The following is a description of a gene set: Correlates of immune-mediated protection to most viral and cancer vaccines are still unknown. This impedes the development of novel vaccines to incurable diseases such as HIV and cancer. In this study, we have used functional genomics and polychromatic flow cytometry to define the signature of the immune response to the yellow fever (YF) vaccine 17D (YF17D) in a cohort of 40 volunteers followed for up to 1 yr after vaccination. We show that immunization with YF17D leads to an integrated immune response that includes several effector arms of innate immunity, including complement, the inflammasome, and interferons, as well as adaptive immunity as shown by an early T cell response followed by a brisk and variable B cell response. Development of these responses is preceded, as demonstrated in three independent vaccination trials and in a novel in vitro system of primary immune responses (modular immune in vitro construct system), by the coordinated up-regulation of transcripts for specific transcription factors, including STAT1, IRF7, and ETS2, which are upstream of the different effector arms of the immune response. These results clearly show that the immune response to a strong vaccine is preceded by coordinated induction of master transcription factors that lead to the development of a broad, polyfunctional, and persistent immune response that integrates all effector cells of the immune system. Human Gene Set: GAUCHER_PBMC_YF_VAX_STAMARIL_UNKNOWN_AGE_10DY_UP species: Homo sapiens Genes up-regulated in peripheral blood mononuclear cell 10d vs 0d in unknown after exposure to YF-Vax/Stamaril, time point 10D from publication Gaucher D, Therrien R, Kettaf N, Angermann BR, Boucher G, Filali-Mouhim A, Moser JM, Mehta RS, Drake DR 3rd, Castro E, Akondy R, Rinfret A, Yassine-Diab B, Said EA, Chouikh Y, Cameron MJ, Clum R, Kelvin D, Somogyi R, Greller LD, Balderas RS, Wilkinson P, Pantaleo G, Tartaglia J, Haddad EK, Sékaly RP (PMID 19047440), and this is the list of marker genes: EPB41L3, MYL6B, PCK2, ASCL2 (NCBI Gene Id 430), PARP9, CX3CR1, IFIH1, OAS2, ASPRV1, SHISA5, SOCS1, SLC27A3, IFI6, TAP1, NAGK, IFI44L, RIGI, FBXO6, IFITM1 (interferon induced transmembrane protein 1), CUL1, MICB, CCR1, RNF135, AIM2, IFI30, FLVCR2, NEXN, TMEM268, TRIM21, LGALS9, NPC2, TRIM38, LAP3, ABCA1, ANKRD22, TRIM5, RRAS, IL1RN, CD38, TRAFD1, EPSTI1, SNTB1, TNFSF10 (TNF superfamily member 10), DHX58, RTP4, NTNG2, AP5B1, UBE2S, BST2, IRF7, SCO2, CYBB, SIL1, GALM, ABI3, CDCA5, TYMS, BLVRA, GADD45B, MCM4, OTOF, STAT2, ISG15, HLA-A, SDF2L1, FRMD3, HAVCR2, MYOF, UBE2L6, MAD2L1BP, ACOT9, GBP1, GCH1, PLSCR1, IFIT3, ADA, DHRS9, SPATS2L, TMEM62, IFI44, TLR7, NUSAP1, TMEM123, SLC31A2, NME1, XAF1 (XIAP associated factor 1), CDC20, OAS3, ACTA2, NMI, PRF1, PARP14, APOL3, IFIT2, IFI16, WARS1, SP110, CALHM6, PSME2, MOV10, IFIT1, GBP5 (guanylate binding protein 5), TENT5A, HERC5, NAGA, UHRF1, RAB8A, ZC3HAV1, PML, SHFL, LMO2, TMEM140, LHFPL2, SUSD1, APOBEC3F, SAMD4A, CCNB2, GPBAR1 (NCBI Gene Id 151306), PARP12, SEPTIN4, ATF3, OAS1, UBA7, JCHAIN, RGS12, TXNDC5, EIF2AK2, TAP2, PHGDH, MT1A, CDCA7, MT2A, STAT1, CHMP5, DDX60, HERC6, SAMD9L, TOR1B, OASL, PARP10, CYSLTR1, IL15, UBE2C, FAM8A1, ADAP2, ACOT7, SAT1, NUB1, IFI35, NCOA7, TXNDC11, RIN2, NAPA, ADAR, HES4, CENPM, TUBG1, HELZ2, GBP2 (guanylate binding protein 2), TK1, BTN3A1, ZBP1, DRAP1, SERPING1, IFITM3, OSBPL5, RSAD2, IRF9, PTTG1, LY6E, PLAC8, CASP1, MT1F, RGL1, CEACAM1, SRBD1, MX1, CTSL, BATF2, REC8, GNGT2, PHF11, LGALS3BP, TRIM22, STMN1, IFI27, SCARB2, IFIT5, DUSP5, TIMM10, RIPK3, VAMP5, TDRD7, IDH2, SP140, SRC